Given this list of marker genes EME2, EME1, XRCC3, MUS81, GEN1, here is a description of the gene set: The cleavage and rejoining of intermediates, mitotic recombination to produce two intact molecules in which genetic material has been exchanged. Human Gene Set: GOBP_RESOLUTION_OF_MITOTIC_RECOMBINATION_INTERMEDIATES studied in species Homo sapiens